Given this list of marker genes H2BC26, SYCP3, H2AJ, H2AC20 (H2A clustered histone 20), H2BC1, SMC1A, SUN1, LMNA, STAG3, H2AB1, HSPA2, LMNB1, TEX12, UBE2I, H2BC3, H2BC4, SYCE3, TINF2, TERF2, H2AC18, SYCE1, ATR, H2AC7, H2AC4, DIDO1, H2BC11 (NCBI Gene Id 8970), H3-4, RAD21, H2AZ2, H2BC5, TERF1, SYNE1 (spectrin repeat containing nuclear envelope protein 1), STAG1, BRCA1, H2BC9, H2AX, SYCP2, TERF2IP, POT1, ACD, SYNE2, SYCP1, H2BC14, SMC3, H4C1, SYCE2, H2BC12L, H2BC17, SUN2, SMC1B, H2BC13, H2BC21, STAG2 (NCBI Gene Id 10735), FKBP6, H2BC15, H2BC12, H2AC14, H2AC6, REC8, here is a description of the gene set: part of: Meiosis species: Homo sapiens Reactome Pathway: Meiotic synapsis Meiotic synapsis is the stable physical pairing of homologous chromosomes that begins in leptonema of prophase I and lasts until anaphase of prophase I. First, short segments of axial elements form along chromosomes. Telomeres then cluster at a region of the inner nuclear membrane and axial elements extend and fuse along the length of the chromosomes. Subsequent to the initiation of recombination transverse filaments of SYCP1 link axial/lateral elements to a central element containing SYCE1 and SYCE2, thus forming the synaptonemal complex.<br>Unsynapsed regions are silenced during pachynema by recruitment of BRCA1 and ATR, which phosphorylates histone H2AX.